Given this list of marker genes MCCC2, PSMC2, RPS4X, OTC (NCBI Gene Id 5009), TYRP1, AIMP2, SLC6A7, BCKDHB, TH, AUH, ADO, MPST, CDO1, MARS1, INMT, RPL27, SERINC5, EEFSEC, AFMID, RPL13A, RPL3, UROC1, RPS3A, PSTK (NCBI Gene Id 118672), PRODH (proline dehydrogenase 1), AMDHD1, IDO1, PSPH, ASL, RPL13, PSMD1, SERINC1, RPS5, RPL11, RPL5, SARDH, RPS18, OCA2, PSMB7, HSD17B10, ACADSB, RPL37, AMD1, RPL30, SDSL, GADL1, ASS1, SLC5A5, SLC25A15, HIBCH, RPL37A, CHDH, PAH, RPL9, AGMAT, GNMT, SARS1, SEPHS2, RPS6, RPS27L, RPL32, RPL22L1, PSMD12, PSMC3, CSAD, HAO1, OAZ2, RARS1, CKM, SCLY, HAL (NCBI Gene Id 3034), SMOX, GLS, AHCY, RPL23A, BCKDK, RIMKLB, SLC25A21, PAPSS2, GSTZ1 (NCBI Gene Id 2954), ACAD8, SDS, MTRR, MTAP, ALDH9A1, RPS2, GLUL, GLYAT, TP53, RPL17, KMO, UBA52, CARNMT1, RPLP1, PYCR1, RPL18, ECHS1, AANAT, SQOR, TXNDC11, PSMD2, ACMSD, PSMA3, RPL23, FAH, QARS1, RPL39, PXMP2, RPS4Y2, RPL26, OAT, SIRT5, AMT, AGXT2, HGD (NCBI Gene Id 727722), HOGA1, HPD, PNMT, SLC25A44, KYAT1, ENOPH1, SLC6A11, GOT1, SLC25A12, CRAT, SERINC2, AIMP1, SRM, PHYKPL, RPL18A, GLUD2, TPH2, GRHPR, RPL10, GPT2, HNMT (NCBI Gene Id 3176), AGXT, SEPSECS, RPS11, BCAT2, RPS13, PSMD7, PSMA4, RPL10A, DIO2, ARG1 (arginase 1), ASRGL1, ACAT1, SRR, TXN2, FOLH1, GLUD1, PSMD6 (proteasome 26S subunit, non-ATPase 6), PSMB5, RPSA, DCT, IVD, GPT, RPS28, DAO, SLC44A2, KYNU, PSMC5, GOT2, RPL39L, ADI1, CTH, CARNS1, RPL38, AADAT, SLC6A8, RPL34, RPS9, BHMT, RPS14, SECISBP2, ALDH18A1, PSMA6, ARG2, RPL29, RPS26, DIO3, DMGDH, RPL3L, FAU, RPS27A, SLC7A5, GSR, SEM1, CPS1, SMS, 18S rRNA, BCKDHA, RPL36AL, TST, SLC36A4, RPS29, DLST, RPL8, SLC44A1, PIPOX (pipecolic acid and sarcosine oxidase), TPO, OAZ3, ASPG, PYCR2, EPRS1, GCSH (glycine cleavage system protein H), SLC25A13, RPS24, SLC6A12, RPL35A, NAGS, IYD, KARS1, PSMB2, PSMB6, RPLP2, CKB, HDC, IARS1, RPS10, IDO2, ODC1 (ornithine decarboxylase 1), ASPA, PSMC1, MTR, SHMT1, AOC1, RPL19, TDO2, RPL31, DUOXA1, RPS20, APIP, RPL35, SERINC4 (NCBI Gene Id 619189), HIBADH, RPL26L1, FOLH1B, RPS16, MRI1, PSMD3, TMLHE, PRODH2, PSMD11, SLC45A2 (NCBI Gene Id 51151), GLS2, 5S rRNA, TPH1, SLC22A4, DDC, PSMD8, CKMT2, HYKK, RPS4Y1, PSMA5, RPS21, RPS19, SAT1, BCAT1, DARS1, ALDH7A1, DIO1, AASS, RPS15, DUOXA2, PSMC6, GCDH, MCCC1, PSMB3, CBS, TXNRD1, RPS17, PSMA1, RPL24, PYCR3, ASNS, RPL7, QDPR, OGDH, RIMKLA, SERINC3, RPL36A, KYAT3, GLDC, SLC25A2, PSMB4, CRYM, PAOX, PHGDH, RPL36, RPL12, RPL27A, ASMT, ETHE1, RPL41, AZIN2 (antizyme inhibitor 2), LARS1, PSMD14, RPL21, DBT, RPS3, DDO, NNMT, RIDA, ADRM1 (NCBI Gene Id 11047), FTCD, RPL15, PSMD13, GAMT, AZIN1, HAAO, TAT, SLC3A2, EEF1E1, RPL10L, DBH, DUOX1, IL4I1, PCBD1, NAALAD2, PSAT1, SLC25A10, RPLP0 (ribosomal protein lateral stalk subunit P0), PSMA7 (NCBI Gene Id 5688), SUOX, OAZ1, PAPSS1, CGA, RPS7, RPS27, FMO1, TYR, NMRAL1, TSTD1, RPL6 (NCBI Gene Id 6128), RPS12, KGD4, RPS25, PSMA2, RPL22, ALDH6A1, RPS23, CAV1, RPL4, RPS8, BBOX1, MAT1A, CKMT1A, PSMB1, RPL14, RPL7A, NQO1, GATM, DHTKD1, 5.8S rRNA, RPS15A, TSHB, ALDH4A1, 28S rRNA, NAT8L, PPM1K, BHMT2, RPL28, DUOX2, DLD, PSMC4, here is a description of the gene set: part of: Metabolism species: Homo sapiens Reactome Pathway: Metabolism of amino acids and derivatives Cellular metabolism of amino acids and related molecules includes the pathways for the catabolism of amino acids, the biosynthesis of the nonessential amino acids (alanine, arginine, aspartate, asparagine, cysteine, glutamate, glutamine, glycine, proline, and serine) and selenocysteine, the synthesis of urea, and the metabolism of carnitine, creatine, choline, polyamides, melanin, and amine-derived hormones. The metabolism of amino acids provides a balanced supply of amino acids for protein synthesis. In the fasting state, the catabolism of amino acids derived from breakdown of skeletal muscle protein and other sources is coupled to the processes of gluconeogenesis and ketogenesis to meet the body’s energy needs in the absence of dietary energy sources. These metabolic processes also provide the nitrogen atoms for the biosynthesis of nucleotides and heme, annotated as separate metabolic processes.<p>Transport of these molecuels across lipid bilayer membranes is annotated separately as part of the module on "transmembrane transport of small molecules".